The following is a description of a gene set: Any protein complex that is capable of carrying out some part of the process of cell-cell adhesion. species: Homo sapiens Human Gene Set: GOCC_PROTEIN_COMPLEX_INVOLVED_IN_CELL_CELL_ADHESION, and this is the list of marker genes: NLGN1, LGALS2, NRXN1, IZUMO1, LGALS1, GLIPR1L1